Given this list of marker genes THEM5, CKS1B, SCAMP3, TDRKH, EFNA3, PYGO2, TRIM46, FLAD1, SHC1, GBA1, THEM4, ZBTB7B, EFNA4, MUC1 (mucin 1, cell surface associated), LENEP, HCN3, PBXIP1, MRPL9, PKLR, EFNA1, ENTREP3, ADAM15, MTX1, DCST2, THBS3, LINGO4, SLC50A1, DPM3, CLK2 (NCBI Gene Id 1196), PMVK, FDPS, RUSC1, RUSC1-AS1, OAZ3, RORC, CELF3, DCST1, KRTCAP2, here is a description of the gene set: Genes within amplicon 1q21 identified in a copy number alterations study of 191 breast tumor samples. species: Homo sapiens A single cancer cell contains large numbers of genetic alterations that in combination create the malignant phenotype. However, whether amplified and mutated genes form functional and physical interaction networks that could explain the selection for cells with combined alterations is unknown. To investigate this issue, we characterized copy number alterations in 191 breast tumors using dense single nucleotide polymorphism arrays and identified genes with copy number gain organized into 30 amplicons. Amplicons were distributed unequally throughout the genome. Each amplicon had distinct enrichment pattern in pathways, networks, and molecular functions, but genes within individual amplicons did not form coherent functional units. Genes in amplicons included all major tumorigenic pathways and were highly enriched in breast cancer-causative genes. In contrast, genes with somatic mutations in breast cancer were distributed randomly over the genome, did not represent a functionally cohesive gene set, and were relatively less enriched in breast cancer marker genes. Mutated and gained genes did not show statistically significant overlap but were highly synergistic in populating key tumorigenic pathways including transforming growth factor beta, WNT, fibroblast growth factor, and PIP3 signaling. In general, mutated genes were more frequently upstream of gained genes in transcription regulation signaling than vice versa, suggesting that mutated genes are mainly regulators, whereas gained genes are mostly regulated. ESR1 was the major transcription factor regulating amplified but not mutated genes. Our results support the hypothesis that multiple genetic events, including copy number gains and somatic mutations, are necessary for establishing the malignant cell phenotype. Human Gene Set: NIKOLSKY_BREAST_CANCER_1Q21_AMPLICON from publication Nikolsky Y, Sviridov E, Yao J, Dosymbekov D, Ustyansky V, Kaznacheev V, Dezso Z, Mulvey L, Macconaill LE, Winckler W, Serebryiskaya T, Nikolskaya T, Polyak K (PMID 19010930)